Given this list of marker genes App, Foxa2, Lin28a, Cdon, Actr3, Rgs6, Fezf1, Tcf12, Vwc2l, Bmp6, Cpne1, Vwc2, Bdnf, Neurod1, Gata2 (NCBI Gene Id 14461), Mmd2, Fgfr1, Timp2, Kctd11, Adra2c, Hoxd3, Nbl1, Dnmt3b, Mir124a-1, Hmg20b, Bmp7, Zeb1, Mmd, Epo, Adra2b, Upf3b, Gprc5b (NCBI Gene Id 64297), Sox11, Neurog3, Dlx2, Shoc2, Tcf3, Brinp3, Mef2c, Bcl6, Nap1l2, Fgf2, Foxg1, Dlx1, Bmp2, Brinp2 (NCBI Gene Id 240843), Mapk8ip3, Brinp1, Gli2, Impact, Ngf, Foxa1, Ncoa1, Etv5, Ect2, Dmd, Rhoa, Pten, Bend6, Map1b (NCBI Gene Id 268696), Trpc5, Bnip2, Neurod2, Gdf7, Neurog2, Sox2, Mir124a-3, S100b, Tgif1, Duoxa1, Ccr5 (NCBI Gene Id 235693), Fezf2, Eif4g1, Il6, Rnf112, Cyb5d2, Trpc6, Ascl1, Zc4h2, Gdf5, Kdm4c, Gdf6, Dkk1, Pax6, Nkx2-2, Sh3gl3, Tcf4, Nkx6-1, Prox1, Tgif2 (NCBI Gene Id 97009), Sall1, Gdpd5, Phox2b, Ccl5, Cxcl12, Nkx2-5, Atoh1, Pcp4, Tle6, Heyl, Dab1, Ngfr, Trim32, Arhgef2, Neurog1, Shh (sonic hedgehog), Mir124a-2, Rara, Rest, Kdm4a, Bmp4, Irx3, Itgb1, Spag9, Sin3a, Ifng, Socs2, here is a description of the gene set: studied in species Mus musculus Any process that activates or increases the frequency, rate or extent of neuron differentiation. Mouse Gene Set: GOBP_POSITIVE_REGULATION_OF_NEURON_DIFFERENTIATION